Given this list of marker genes EPS8, STON1, EPS8L3, ARHGAP24, PFN2, USP17L2, PLEKHM1, SNX10, HRAS, CORO1C, RAC1, AIF1L, STAP1, INPPL1, NLGN1, NDEL1, KANK1, RDX, CAV1, INPP5K, P2RX4, PIP5K1A, AIF1, EVL, ARF6, PFN1, RHOG, WDPCP, ABI3, EPS8L2, ICAM1, SH3BP1, EPS8L1, P2RY12, FAM98A, TACSTD2, BAG4, ARHGEF26, SH3YL1, DEF8, RCC2, COBL, CSPG4, CARMIL2 (capping protein regulator and myosin 1 linker 2), here is a description of the gene set: The aggregation, arrangement and bonding together of a set of components to form a ruffle, a projection at the leading edge of a crawling cell; the protrusions are supported by a microfilament meshwork. The formation of ruffles (also called membrane ruffling) is thought to be controlled by a group of enzymes known as Rho GTPases, specifically RhoA, Rac1 and cdc42. species: Homo sapiens Human Gene Set: GOBP_RUFFLE_ASSEMBLY